The following is a description of a gene set: Any process that stops, prevents, or reduces the frequency, rate or extent of the covalent alteration of one or more amino acid residues within a protein. species: Mus musculus Mouse Gene Set: GOBP_NEGATIVE_REGULATION_OF_PROTEIN_MODIFICATION_PROCESS, and this is the list of marker genes: Lilrb4a, Plaa, Trim44, Rela, Cops9, Bag5, Jun, Spag9, Atg5, Ufl1, Ptprh (protein tyrosine phosphatase receptor type H), Men1 (NCBI Gene Id 17283), Ocln, Sh3bp5, Ptprj, Dusp6, Ppia, Usp4, Pinx1, Parp10, Spry2, Impact, Sumf2, Vps28, Nf2, Rpl5, Smad7, Cadm1, Fyn, Ccnb1, Inpp5f, Prkch, Hhatl, Bag2, Gstp-ps, Prr5l, Prkcd, Adar, Chmp6, Hdac8, Socs5, Errfi1, Ppm1f, Bex4, Spred2, Isg15, Hipk3, Fem1a, Ttc36, Mvp, Tspo, Slit2, Cadm4 (cell adhesion molecule 4), Ptgis, Heg1, Hmg20a, Eif4g1, Ctnnb1, Lats1, Bex1, Kirrel2, Fabp4, Mgat4d, Dmtn, Trim27, Cactin, Ubxn1, Lilrb4b, Cnksr3, Trim21, Pbk, Socs4, Sh3gl2, Pten, Rgs14, Snta1, Dusp22, Nxn, Gbp4, Sirt2, Tnfaip3, Fbxo5, Ptprb, Dnajc3, Nup62, Rabgef1, Gstp2, Sh3rf2, Acp4, Mapk8ip1, Pax6, Irf1, Hdac2 (histone deacetylase 2), Cib1, Sfrp1, Dusp10, Fry, Dgkq, Spry1, Rps23rg1, Abl1, Sfrp2, Cdkn2c, Casp3, Tgfb1, Dkk1, Ppp1r15a, N4bp1, Ptprt, Mir26b (microRNA 26b), Garem1, Parp14, Usp44, Rps7, Rasip1, Pibf1, Itgb1bp1, Cdkn1b, Klhl40, P3h1, Kat2b, Rgn, Drd2, Gpd1l, Dab2ip, Ptpn22, Rack1, Gadd45b, Prkrip1, Ppef2 (NCBI Gene Id 19023), Ceacam1, Ptprc, Sh2d1b1 (NCBI Gene Id 26904), Klhl31, Kirrel1, Igfbp3, Hnf1a, Mtor, Samsn1, Bex6, Pard6a, Rasd2, Enpp1, Srcin1, Cry1, Gnaq, Ntf3, Socs3, Flcn, Nolc1, Macroh2a1, Wwtr1, Dtnbp1, Lats2, G6pd2, Park7, Stk38, Caml, Ctdsp2, Per2, Sfrp5, Sirt3 (sirtuin 3), Dnaja1 (NCBI Gene Id 18001), Hspa4, Sox4, Dnajb2, Prkaa1, Tfap4, Ubash3b, Ppargc1a, Tsc2, Tsg101, Blvra, Slfn1, Uchl1, Bag1, Prkdc, Bdkrb2 (NCBI Gene Id 12062), Fscb, Qars1, Ptpn13, Ptpn6, Cdk5rap3, Taf7, Nppa, Zgpat, Apc, Ptk6, Slc8a1, Adgrb1, Ogt, Ivns1abp (NCBI Gene Id 98245), Senp2, Nck1, Prkn, Bak1, Dtx3l, Gba1, Gprc5a, Smyd3, Fbln1, Niban1, Pkn1, Wee2, Dusp3, Ibtk, Gstp3, Mllt1, Crtap, Slc8a3, Ager, Capn3, Agt, Ctdspl, Tardbp, Nnt, Terf2ip, Cdkn1a, Nf1 (NCBI Gene Id 320618), Gadd45g, Gclc, Angpt1, Ggnbp2, Hyal2, Myadm, Pid1, Rtraf, Zc3h12a, Arrb2, Pebp1, Prkce, Dcun1d3, Met, Ptpro, Shb, Klf15, Pkia, Ptpn1, Bdkrb1, Cd300a (NCBI Gene Id 217303), Nlrp12, Igf1, Rassf2, Cd109, Tmed2, Oxr1, Mas1, Inpp5k, Prkag2, Il2, Wnk4, Myocd, Gadd45a, Il18, Bax, Grk2, Gnl3l, Dnajc10, Trib1 (NCBI Gene Id 211770), Prmt3, Hspb1, Irak3, Psen1, Rb1, Rpl23, Adarb1, Deptor, Wnk1, Cblc, Ncoa7, Psen2, Fkbp8, Socs1, Bmp2, Tbc1d24, Dvl1 (NCBI Gene Id 13542), Gtpbp4 (GTP binding protein 4), Pip5kl1 (NCBI Gene Id 227733), Mapt, Zfyve28, Chordc1, Spry4, Dnaja3, Plk1, Cep63, Inca1, U2af2 (U2 small nuclear ribonucleoprotein auxiliary factor (U2AF) 2), Cdk5rap1, C9orf72, Svbp, Crkl, Smo, Ppp4c, Xdh, Sqstm1, Mir26a-2, Ppm1e, Bex3, Inpp5j, Prkcg, Mir26a-1, Cep78, Il1b (interleukin 1 beta), Pard3, Gstp1, Gskip, Snca, Sirt7, Spred1, Dbndd2, Pabpn1l, Dysf, Pdcd4, Akt1s1, Sirt1, Oga, G6pdx, Hspa1b, Spopl, Rpl11, Smpd1, Wars1 (tryptophanyl-tRNA synthetase1), Minar1, Tppp, Lyn, Suz12, Epm2a, Coro1c (coronin, actin binding protein 1C), Ntrk3 (NCBI Gene Id 414121), Npm1, Hhex, Zbed3 (zinc finger, BED type containing 3), Plpp3, Peli3, Plec, Insr, Pycard, Cdkn1c, Cdyl, 2610042L04Rik, Ctdsp1, Gsk3b, Dusp19, Dbi, Prkaa2, Pkig, Chp1, Aida, Cdkn2a, Insm1, Fbxo7, Gps2 (NCBI Gene Id 56310), Pias3, Cav3, Ptpn2, Ppp1r15b, Mlxipl, Marchf7, Mad2l1, Limk1, Cdk5, Apoe, Prkar1a, Spink1, Paqr3, Tesk1, Nr2f2, Cep85, Vps25, Zfp418, Fxyd1, Hmgcr, Cep43, Dusp1, Arrb1, Hint2, Pecam1, Epha1, Hnf4a, Pparg, Gfra2, Thy1, Ifng, Hgf, Ppp2r5d, Pkib, Mad2l2, Prkcz, Adipoq, Akt1, Traf3ip1, Bex2, Lrp6, Dusp7, Cav1, Ube2b, Lrrk1, Rps3, Ppp5c, Rgs2, Hmg20b, Atg14, Trib3, Hexim2, Prkca